Given this list of marker genes ACP5, ENPP1, RFK, SLC52A3, SLC52A1, SLC52A2, FLAD1, here is a description of the gene set: Riboflavin (vitamin B2, E101) is an essential component for the cofactors FAD (flavin-adenine dinucleotide) and FMN (flavin mononucleotide). Together with NAD+ and NADP+, FAD and FMN are important hydrogen carriers and take part in more than 100 redox reactions involved in energy metabolism. Riboflavin is present in many vegetables and meat and during digestion, various flavoproteins from food are degraded and riboflavin is resorbed. The major degradation and excretion product in humans is riboflavin. species: Homo sapiens Reactome Pathway: Vitamin B2 (riboflavin) metabolism part of: Metabolism of water-soluble vitamins and cofactors